Given this list of marker genes LY9, ARL3, SIX3, LSM12, NFRKB, SLC2A1, LMO1, IRF2BP1, LCOR, HSPB2, ZNF500, CD8B, SLC6A9, AAK1, SLC18A1, SMYD5, CD6, KIFC3, AGPS, FRYL, WT1, BRD1, MYO9B, ADCYAP1 (NCBI Gene Id 116), MR1, ZKSCAN3, STK17A, DTNA, POU6F1, ADAMTSL2, ENTREP1, ITPR2, NF1, SLC30A1, ALDOC, MGP, SYT5, DRC3 (dynein regulatory complex subunit 3), JAK3, JRK, FOSL1, CRYAA, TBC1D22A, CDK5R1, AQP7, TM4SF5, MT4, SEZ6L, GPR3, FLT1, HTR1B, ZNF292, SH2B1, LEFTY1, NEUROD2, IRF2, CLPX, TMSB4Y, CTRL, SSTR5, SLC13A2, BCL2, KANK2, CLOCK, IPCEF1, ETV3, SPEF1, ARSL, TBX19, TUBGCP4, PML, COLQ, SLC6A7, RPS6KB2, CRHR2, DPT, F7, SLC5A2, CEP135, BPHL, RBBP8, TMEM94, TNKS, ECE2, TNFRSF25, SLC25A11, PIGR, COX6A2, KRT33A, MC2R, TMEM11, ARC, CDK13 (NCBI Gene Id 8621), UGT2B15, GJB5, SLC22A24, ADAM15, LTK, CMA1, HOXD4, TBX5, C1orf216, DDX11, RUNX1, IL13, EXTL3, PRELID3A, TLN2, CLBA1, LTBP4, LBP, MC5R, PAX9, SLC16A5, PAXIP1, KAT8, ADCY3, KCNMB1, RASSF1, GTSE1, BMP10, MSL3, AMFR, LINC00837, AQP5 (NCBI Gene Id 8084), N4BP2L2, FANCG, GRIK5, FDXR, TMPRSS6 (NCBI Gene Id 164656), OPRL1, NOS2, BNIP1, GPR35, GSTM5, DTX4, PCBP3, ZP2, POU6F2, DNAJC16, MSX1, KCTD20, ABCB9, CCKAR, BAHD1, FUT6, NCKIPSD, PAX7, MLN, ERC1 (ELKS/RAB6-interacting/CAST family member 1), ITIH4, NRP2, CYP11A1, PVT1, POLR2K, ZNF710, SDC3 (syndecan 3), HAUS5, ELAVL2 (NCBI Gene Id 1993), HTR4, KLHL18, SLC4A3, KRR1, AANAT, DOK1, PIGB, KRT1, DKK4, FNTB, ESR1, ABO, ATP6V1B1, ACKR2, PLEKHB1, IVL, PARVB, PRKACA, AFF2, NRTN, ZNF592, KANK3, SLC22A6, SLC30A3, SMPDL3B, ATRX, TFDP2, JAG1, HTR7, WDR62, SLC6A11 (solute carrier family 6 member 11), MMP25, UTRN, P2RY10, SLC24A1, PRSS16, SLC12A4, CAMK2G, CYP2A6, ECE1, IKBKE, CD3E, GPATCH8, NXPE3, EPHB2, SCAPER, ATP6V0A2 (ATPase H+ transporting V0 subunit a2), PIK3CB, KRT86, PCGF1, GRIP2, IMPA1, CRCP, DAPK2, CNTN2, MPP2, SULT4A1, HSD17B3, TIE1, MOK, NEURL1, MYC, GLE1, PAX8, here is a description of the gene set: studied in species Homo sapiens Neighborhood of BCL2 Human Gene Set: MORF_BCL2 Neighborhood of BCL2 B-cell CLL/lymphoma 2 in the MORF expression compendium